The following is a description of a gene set: from publication Dower K, Ellis DK, Saraf K, Jelinsky SA, Lin LL (PMID 18292579) Genes up-regulated in comparison of monocytes treated with 5000 ng/ml LPS (TLR4 agonist) versus monocytes treated with control IgG. TREM-1 is an orphan immunoreceptor expressed on monocytes, macrophages, and neutrophils. TREM-1 associates with and signals via the adapter protein DAP12/TYROBP, which contains an immunoreceptor tyrosine-based activation motif (ITAM). TREM-1 activation by receptor cross-linking is pro-inflammatory, and can amplify cellular responses to Toll-like receptor (TLR) ligands such as bacterial lipopolysaccharide (LPS). To investigate the cellular consequences of TREM-1 activation, we have characterized global gene expression changes in human monocytes in response to TREM-1 cross-linking in comparison to and combined with LPS. Both TREM-1 activation and LPS up-regulate chemokines, cytokines, matrix metalloproteases, and PTGS/COX2, consistent with a core inflammatory response. However, other immunomodulatory factors are selectively induced, including SPP1 and CSF1 (i.e., M-CSF) by TREM-1 activation and IL-23 and CSF3 (i.e., G-CSF) by LPS. Additionally, cross-talk between TREM-1 activation and LPS occurs on multiple levels. While synergy in GM-CSF protein production is reflected in commensurate mRNA abundance, comparable synergy in IL-1b protein production is not. TREM-1 activation also attenuates the induction of some LPS target genes, including those that encode IL-12 cytokine family subunits. Whereas positive TREM-1 outputs are abolished by the PI3K inhibitor wortmannin, this attenuation is largely PI3K-independent. These experiments provide a detailed analysis of the cellular consequences of TREM-1 activation, and highlight some of the complexity in signal integration between ITAM- and TLR-mediated signaling. Human Gene Set: GSE9988_LPS_VS_CTRL_TREATED_MONOCYTE_UP species: Homo sapiens, and this is the list of marker genes: EDN1, PLEK, PLK3, SGPP2, OSR2, PTS, TMPO-AS1 (NCBI Gene Id 100128191), PTGS2, STK26, XBP1, PLAUR, DUSP2, IER3, IL6, EFNA1, MFSD2A, TPD52, ANO5, SOCS3, FAM177A1, KCNJ2, RGS1, FOXO3, RGL4, TMEM88 (transmembrane protein 88), ETS2, NEMP1, RAP2C (RAP2C, member of RAS oncogene family), CD274, TP53BP2, PSMD5, RBM17, DNAJB4, NLRP3, MAP3K4, FFAR2, TDH, CXCL2, SERPINB8, SAV1, CXCL3, TFRC, ADTRP, FJX1, MMP7, PHF1, PTGER4, ELL2, LINC01465, RND1, BCL2A1, HECW2, BTG2, CXCL8, CSRNP1, BTG3, CCR7, CSF3, BIRC3, G0S2, RAB21, DYRK3, NOCT, E2F7, DDX5, IL18, SYNPO2, ZC3H12A (NCBI Gene Id 80149), CDK1, F8, SELENOK, RYBP, IL1B, GBP2, SUSD6, NFKBIZ, B3GNT2, SOD2, ICAM1, KRTAP5-8 (NCBI Gene Id 57830), HS3ST3B1, PPP1R15B, LAMA3, IL12B, ADORA2A-AS1, RAB33A, YRDC, GPR84, C11orf96, BSND, PLEKHF2, LINC01093, PIGA, ATP2B1-AS1, PTP4A1, PHLDA2, TIFA, DRAM1, UBE2D1, C1QTNF1, ACSL1, RGCC, PNRC2, POLR1F, CT75, REL, IL6ST-DT, STARD4, EGR1, RIN2, TXN, TAOK3, NFKBIA, MIR155HG, HNRNPC, RAPGEF2, GADD45A, CCSER2, DUSP1, MARCKS, ARL5B, ADAMDEC1, PFKFB3, CDKN1A (cyclin dependent kinase inhibitor 1A), NEDD4L, IL1A, CD83, IL10, IL36G, GNG2, CYB5D1, GCH1, CFLAR-AS1, NUP58 (NCBI Gene Id 9818), TNFAIP3, DCUN1D3, MIR9-1HG, PDSS1, CFLAR (NCBI Gene Id 8837), PTX3, DENND4A, MAFF, GBP1, RHOH, TNF, PPP1R15A, DNAAF1, WTAP, DDIT4, AQP9, ZFC3H1, RTP3, RPGR, KDM7A-DT, MIR3945HG, CLCF1, MIR3142HG, RHCG, SGMS1, EIF1B, HIVEP2, SIAH2, USP12, IL23A, DUSP5, SFR1, PIM3, AREG, FOSL1, TNIP3, STAT5A, NEK2-DT, IL6-AS1, GADD45B, CCL4, NAF1, RBBP8, CCL18, CCL23, MAP3K8, PLD1, TNFAIP6, DLGAP1-AS2, HES1, LINC-PINT, ZNF674-AS1, RIPK2, CXCL1, DENND5A, ACOD1, INHBA, PELI1, ADM, ID2, SPECC1L, DLGAP1-AS1, CCRL2